Given this list of marker genes HNRNPDL, DAZAP1, PNPT1, MCRS1, ATXN1, HNRNPU, FMR1, PATL1, here is a description of the gene set: Binding to a sequence of guanine residues in an RNA molecule. species: Homo sapiens Human Gene Set: GOMF_POLY_G_BINDING